Given this list of marker genes TADA3, GALM, USP10, INSIG2, THBS3, SLU7, SMKR1, TARS1, AVPI1, ATP2B4 (ATPase plasma membrane Ca2+ transporting 4), UQCRHL, DPH1, AIMP1, EGLN2, PCDHAC1, KLC1, GBA2, PGM1, FGD1, UBE2T, MRPS10, KCNS1, MAT2B, AMBP, PACSIN1, CMPK1, PLEKHG3, TRAK1, NPRL3, WHAMM, SEMA3G, SNHG12, CLEC12B, MRPS16, NPTX2, COX4I1, MTCL1, AAMDC, AKNA, ABHD1, DGAT1, KDM4A, IL17RA (NCBI Gene Id 23765), EXOC7, ESCO2, CTNNBIP1, PDE7B, SENP3, ZPR1, NOL9, AARD, NEK7, EGR1, IRS2, SSC4D, DAGLB, AKT1S1, CNIH4, KAZALD1, VWC2, PAK6, MADD, ACBD6, MYOZ2, C1QTNF12, AURKB, DSTYK, LYRM7, IMMP1L, PSKH1, HS3ST3B1, ITGAM, FSTL4, DMTN, CARD6, FOS, NOP53, ADAM8, LENG9, TNFRSF1A, GM2A, ZBTB9, RNPEP, NONO, DLGAP2, CFAP251, PPP1R1B, GPX8, MRPS35 (mitochondrial ribosomal protein S35), RPL24, TBC1D9B, ASB6, RPS23, BUD13, MPZL2, RNF31, PMVK, ORC3, PIK3CD, FAM118A, CCDC86, TMUB1, CLDN10, TOR4A, TRABD, USB1, HSD17B4, TCF19, HPGD, BACH2, GLIPR1, DNAJC3, PPP1R14C, ERI3, KIF1B, LENG1, PHF21A, WDR46, PSMA2, MORF4L2, ELK4, MBD6, ITGAE, ARMC7, NEIL3, CDC27, OCRL, EGR3, KCNMB4, DZIP1, CANT1, RELB, WNT5B, THUMPD2, CADM2, SURF6, JOSD2, PWWP2B, KIT, CDKN2C, PROP1, LMNA, GTPBP1, ASIP, NUDT7, FHIT, FAF1 (Fas associated factor 1), NPTX1, F12, ZBTB26, C5orf15, COP1 (NCBI Gene Id 64326), MPL, ABHD6, PSMB3, HCLS1, KCTD17, GTF2F2, UCKL1, SFTPB, TBX21, SMIM17 (small integral membrane protein 17), PQBP1, KRTAP8-1, TANGO6, KATNA1, BLOC1S5, ENC1, RCC1, MED11, SLC35D1, ERLEC1, LONP1, ZFAND3, JUNB, HSF1, SLC39A3, IER3IP1, CRTC3, IFFO1, OTULIN, MAGI1, SAMHD1, NCOA7, TBC1D22B, SLC39A13, SLC35F1, FN3KRP, CEP19, RBKS, ISY1, SMYD2, EGR2, PABPC4 (poly(A) binding protein cytoplasmic 4), RIN3, ELP6, SUMO3, HSD17B11, here is a description of the gene set: from publication Szanto A, Balint BL, Nagy ZS, Barta E, Dezso B, Pap A, Szeles L, Poliska S, Oros M, Evans RM, Barak Y, Schwabe J, Nagy L (PMID 21093321) Human CD14 positive monocytes were purified from healthy volunteers’ blood and cultured in vitro for 4, 12, 24, 72 hours. While culturing, macrophages were activated alternatively with interleukin-4 (IL-4 100 ng/ml) or classically with interferon-gamma (IFNg 100 ng/ml)+tumor necrosis factor (TNF 50 ng/ml) or left without activation. Simultaneously, macrophages were also treated with vehicle (DMSO:ethanol) or 1mM synthetic PPARg agonist, Rosiglitazone. We used Affymetrix microarrays (U133Plus 2.0) to analyze activation and PPARg-induced gene expression changes. Human Gene Set: GSE16385_MONOCYTE_VS_12H_ROSIGLITAZONE_IFNG_TNF_TREATED_MACROPHAGE_UP studied in species Homo sapiens Genes up-regulated in monocytes (12h) versus macrophages (12h) treated with IFNG, TNF and rosiglitazone.